Given this list of marker genes EMP2, TCF3, COG6, ITK, ALDOA, RAG2, MT-TV, CTLA4, G6PD, MTHFS, MT-TF, ATP1A2, NPHS2, CD3D, HAVCR2, CBLB, CD247, ZNF699, SEMA4D, RMRP, ABL1, ERCC2 (ERCC excision repair 2, TFIIH core complex helicase subunit), TNFSF4, SRSF2 (serine and arginine rich splicing factor 2), IRF1, AVPR2, STAT5B, PTPN22, ACAT1, ERAP1, NUP85, CFTR, RNF31, TMEM165, ARHGAP24, AVP, C1QB, TNFRSF1B (TNF receptor superfamily member 1B), COL1A1, LPIN2, GCH1, PRKAR1A, EPB42, CFHR1, FIP1L1, MCTS1, TSPOAP1, BCAP31, PAX2, DOCK2, KRT18, RARA, IL12A-AS1, MT-TL1, STK4, C4B, WT1, STAT4, BCL10, MT-CO1, PTS, PDCD1, ZFYVE19, OTULIN, IL10, EDA, ACTN4, CRB2, LAMC2, JAZF1, EIF2AK3 (eukaryotic translation initiation factor 2 alpha kinase 3), FCGR2B, STAT6, GATA2, HEPHL1, RANBP2, REST (RE1 silencing transcription factor), DST, CYBC1, TLR4, XPA, ANKFY1, BLK, PMM2, SLC22A4, BIRC3, SCNN1B, NRAS, ARHGDIA, MT-ND5, SH2B3, IGHM, LCK, ZFHX2, TNFRSF1A, CALR, ANK1, CFHR3, ZBTB16, DEF6, OBSCN, FAS, BLNK, BRAF (B-Raf proto-oncogene, serine/threonine kinase), PTPRC, MIF, GPC3, NUP160, APOL1, IRF5, GAA, HMBS, IL2RG, WAS, ORAI1, CYP21A2, SLC19A1, ELF4 (NCBI Gene Id 2000), DPP9, DNASE1, RNASEH2A, CIITA, STING1, SLC34A2, HLA-B, MT-TK, ZNFX1, BACH2, LIG4, POU6F2, MT-ATP6, RNASEH2B, SLC5A1, KLHL7, ASXL1, TSC2, PKHD1, HLA-DPA1, ELANE, WIPF1, TH (tyrosine hydroxylase), UQCRH (NCBI Gene Id 7388), IFNGR1, CD27, RAG1, CHD7, ELP1, NUP205, PRKCD, OFD1, F5, SCYL1, ANKH, PTPN3, LAMA3, CD3E, SCO2, JAK2, H19, TLR7, DNASE2, STAT2, SAT1, GALC, AP1S3, INF2, MT-CYB, DIS3L2, CLPB, LPIN1, NCF4, QDPR, TCIRG1, PSTPIP1, PSMB4, COG7, EPB41, TRNT1, CTRC, MCM10, BCL6, MVK (mevalonate kinase), SPTA1, NAB2, MT-ND2, MYCN, NLRP1, BANK1, TBC1D8B, LSM11, MST1, IL36RN, CYBA, FAH, LYST, TNIP1, IL2RB, TCF4, FOCAD, STXBP2, CPOX, TRIM28, POMP, LACC1, GPR35, LIFR, ABCC2, IRF2BP2, BCOR, TREX1, CD79B, KCNJ1, IKZF1 (IKAROS family zinc finger 1), WDR1, PSAP, MT-ND3, PIK3R1, ENPP1, CYBB, PHOX2B, KIAA0319L, NUMA1, SPTBN1, TRAF3, SLC41A1, HLA-DRB1, ALPL, NUP37, ADAR, CEBPE, MT-ND1, SPINK1, FBP1, XPC, MALT1, SPP1, IL23R, SLC29A3, CD2AP, NPHS1, PXK (PX domain containing serine/threonine kinase like), NCF2, SHARPIN, AK2, ROS1, LIPA, MPL, MAP2K1, IRAK1 (interleukin 1 receptor associated kinase 1), STIM1, UNC93B1, CHEK2, MAGI2, HNRNPK, MYO1E, DAAM2, SH2D1A, HMGCL, UBE2L3, C3, SCNN1A, NFKBIL1, IBA57, NLRP12, IL1R1, LYN, XIAP, RIPK1 (receptor interacting serine/threonine kinase 1), IGHG1 (NCBI Gene Id 3500), RUNX1, TP53, IGLL1, PSMB10, FOXP1, TRPC6, RNASEH2C, MT-CO3, MEFV, IL7R, MECP2, MT-TS2, NOD2, SPI1, ERCC3, BCL2, UBA1 (NCBI Gene Id 8247), RAB27A (NCBI Gene Id 5873), ETS1, ANLN, PLCE1, GYPC, NDUFA2, ALPK1, PTPRO, AQP2, BRCA1, FCGR3B, IRAK4, SLC4A1, LMO1, NUP107, IL12B, ATP5F1B, MLX, RBCK1, SLC12A1, NFU1, IRF8, GLA, CCR1, RYR1, DDB2, CYP11B2, CFH, TICAM1, CACNA1S, PRSS2, ERCC5, CRLF1, C2orf69, PEX6, STX11, RNU7-1, SMARCAL1, BTK, GFI1, MT-ND6, TLR3, NUP133, PSMG2, IL12A, STAT1, IFIH1, PMP22, NKX2-1, PIK3CG, PRTN3, NLRP3, IL6, TRIP13, ABCC6, KIT, PSMB8, TBL1XR1, PSMB9 (NCBI Gene Id 92051), TBK1, ERCC4, NUP93, SLC19A3, CD28, CD244, MRPS7 (NCBI Gene Id 64967), HLA-DPB1, BCR, BTNL2, P4HA2, ALK, NGLY1, CASK, NPM1, UBAC2, SCNN1G, TSC1, MT-ND4, BRCA2, CD79A, IL2RA, KLRC4, ASAH1, NLRC4, PML, ATM, NABP1, PRSS1, POLR3A, P4HTM, MT-CO2, SAMHD1, PTPN2, NCF1, SPTB, RB1, PTPN6, DCLRE1C, CRLS1, LRRC8A, LIN28B, RNU4ATAC, REL, NTRK1, IRF4, KIF1B, STAT3, CD70, ATP13A2, SLC39A7, SLC12A3, CACNA1A, EIF2B1, COL4A3, CPT2, HTR1A, MT-TQ, SRP19, SYK, PRF1, TNFRSF11B, PRNP, ADA, TNFAIP3, CCND1 (NCBI Gene Id 893), IFNG, C4A, LBR, MT-TH, UNC13D, HBB, TRANK1, HACE1, H4C5, ITGAM, LAMB3, ANKRD55 (NCBI Gene Id 79722), ADA2, CR2, RNF168, TET2, NGF, SLC35C1, NAXD (NAD(P)HX dehydratase), COQ8B, MT-TW, MYD88, GAPVD1, ADAMTS13, here is a description of the gene set: species: Homo sapiens Fever Body temperature elevated above the normal range. Human Gene Set: HP_FEVER